The following is a description of a gene set: The chemical reactions and pathways resulting in the formation of a very long-chain fatty acid. A very long-chain fatty acid has an aliphatic tail containing more than 22 carbons. studied in species Mus musculus Mouse Gene Set: GOBP_VERY_LONG_CHAIN_FATTY_ACID_BIOSYNTHETIC_PROCESS, and this is the list of marker genes: Hacd1, Hacd3, Elovl4, Elovl1, Tecrl, Hacd4, Elovl7, Elovl3, Elovl2, Elovl5, Hacd2, Tecr, Elovl6